The following is a description of a gene set: Mouse Gene Set: GOBP_DNA_DAMAGE_RESPONSE_SIGNAL_TRANSDUCTION_BY_P53_CLASS_MEDIATOR studied in species Mus musculus A cascade of processes induced by the cell cycle regulator phosphoprotein p53, or an equivalent protein, in response to the detection of DNA damage., and this is the list of marker genes: Atrx, Ndrg1, Spred2, Smyd2, Pml, Twist1, Usp10, Npm1, Triap1, Spred1, Casp2, Kdm1a, Cdkn1a, Rbm38, Cdkn2a, Dyrk1a, Znhit1, Kat5, Hic1, Brca2, Sp100, Hipk2, Mdm2, Snai1, Rps27l, Trp53, Ddx5, Marchf7, Sirt1, Ifi204, Psmd10, Rpl26, Bcl3, Ing4, Atr, Foxm1, Pidd1, Ppp2r5c, Muc1, E2f7, Atm, Zfp385a, Ifi211, Snai2, Chek2 (NCBI Gene Id 50883), Sesn2, Batf, Ifi205, Pcbp4, Myo6, Ppm1d, Cd74, Ndufs6, Sox4 (NCBI Gene Id 20677), Rps6ka6, Acer2, Kmt5a, Cd44, Cops3, Mdm4, Yju2, Dyrk3, Ptprv, Pttg1ip, Pmaip1, Eef1e1, Prap1, Cradd (NCBI Gene Id 12905), Ankrd1, Zmpste24, Foxo3, Pla2r1 (NCBI Gene Id 18779), Tfap4, Paxip1, Mif